The following is a description of a gene set: species: Homo sapiens Reactome Pathway: Signaling by RNF43 mutants part of: Signaling by WNT in cancer RNF43 and related protein ZNRF3 are E3 ubiquitin ligases that negatively regulate WNT signaling by downregulating FZD receptors at the cell surface. Frameshift loss-of-function mutations in RNF43 that enhance WNT signaling have been identified in pancreatic and colorectal cancers; the proliferation of these cells is dependent on the presence of secreted WNT, as their growth is abrogated by treatment of cells with the Porcupine inhibitor LGK974., and this is the list of marker genes: FZD6, RNF43, LRP6, FZD4, LRP5, FZD5, FZD8, WNT3A